The following is a description of a gene set: Human Gene Set: HP_RENAL_POTASSIUM_WASTING High urine potassium in the presence of hypokalemia. species: Homo sapiens Renal potassium wasting, and this is the list of marker genes: KCNJ10, ATP1A1, SLC12A1, SLC12A3, CLCNKB, KCNJ1